Given this list of marker genes MKKS, SCAPER, SCLT1, CEP290, WDPCP, BBS9, WT1, BBS5, DYNC2LI1, CFAP418, NPHP1, BBS2, GLI3, BBIP1, BBS4, ARL6, TTC8, IFT172, IFT74, LZTFL1, MKS1, BBS12, BBS10, SDCCAG8, BBS1, BBS7, TRIM32 (tripartite motif containing 32), IFT27, CEP19, here is a description of the gene set: studied in species Homo sapiens Hydrometrocolpos Hydrometrocolpos is an accumulation of uterine and vaginal secretions as well as menstrual blood in the uterus and vagina. Human Gene Set: HP_HYDROMETROCOLPOS